The following is a description of a gene set: Pill-rolling tremor Human Gene Set: HP_PILL_ROLLING_TREMOR studied in species Homo sapiens A type of resting tremor characterized by simultaneous rubbing movements of thumb and index fingers against each other., and this is the list of marker genes: PRKN, DNAJC6, PLA2G6, SMC1A, NTNG1, CDKL5, GABBR2, MECP2